The following is a description of a gene set: studied in species Mus musculus Mouse Gene Set: GOMF_STEM_CELL_FACTOR_RECEPTOR_BINDING Binding to a stem cell factor receptor (SCFR), a type III transmembrane kinase receptor., and this is the list of marker genes: Kitl, Spred1, Sh2b3, Spred2, Spred3